The following is a description of a gene set: The increase in size or mass of a lung. In all air-breathing vertebrates the lungs are developed from the ventral wall of the oesophagus as a pouch which divides into two sacs. In amphibians and many reptiles the lungs retain very nearly this primitive sac-like character, but in the higher forms the connection with the esophagus becomes elongated into the windpipe and the inner walls of the sacs become more and more divided, until, in the mammals, the air spaces become minutely divided into tubes ending in small air cells, in the walls of which the blood circulates in a fine network of capillaries. In mammals the lungs are more or less divided into lobes, and each lung occupies a separate cavity in the thorax. species: Mus musculus Mouse Gene Set: GOBP_LUNG_GROWTH, and this is the list of marker genes: Spry2, Pdgfra, Fgf10, Tmem38b, Fgf7, Rspo2, Pdgfrb